Given this list of marker genes GHITM, ARHGEF3, TNFRSF1A, TEFM, CYSLTR2, SLC35A3, RAP1B, ANKRD17, MS4A3 (NCBI Gene Id 95934), CEP19, FKBP1A, PEX13, TGIF1 (NCBI Gene Id 91941), DGKA, ASTN1, RELA, SCIN, ESRP1, SH3BP4, GLA, CACUL1, GALR1, ADAMTS4, GBP4, PEX7, TMEM168, SLC35F6, MTSS1, CREBRF, TAX1BP1, RNF214, C6orf62, IER5, ZFP62, ALCAM, RSBN1, NDUFS4, DNAJB6, BRCA1, CCRL2, DLX1, MOCS2, ARVCF, KLF6, COPZ1, STX2, DNAJB8, ENPP4, PKIG, MRPL30, UPF2, ARL6IP6, RIPK2, TRDMT1, ARMCX3, HERPUD2, UBE2D2, TK1, GOLPH3L, CMTR1, CASP8, CHUK, PCSK7, BCO2, ETV2, ARG1 (NCBI Gene Id 383), BCKDHB, GRAMD1A, KRT81, SLF1, HLA-E, PLOD3, ATP11C, MYO5A, KCTD4, FABP4, MXD1, DUSP1, MAPKAP1, TLR8, UBC, PARP14, ATP11B, OTUB1, SGK1, RNF138, ZNF35, FBH1, NINJ1, PLAT (plasminogen activator, tissue type), KLRK1, STX7, SPN, TMEM45B, LY86, EBI3, IL7R, ZBTB2, LNX2, NMT2, AVL9, TLK2, STK4, TLCD1, IDNK, CSRP1 (cysteine and glycine rich protein 1), UBL5, UBE2R2, DNAJC13, TCAF2 (TRPM8 channel associated factor 2), CD80, RNF114, SELENOT, RNF115, SUOX, SLAMF8, WARS1, HSPA1A, CPEB4, MAPK9, AP3M2, GCNT2, SIRT1, FOS (Fos proto-oncogene, AP-1 transcription factor subunit), PSMA5, TRIP10, TBK1, SLC40A1, FOSB, FYTTD1, CDKN2A, LTA, CLN8, ATG9B, CPNE3, CASP1, MS4A7, STRN3, TASOR2, TRA2A, CHMP4B, DNAJA1, PSMB8, ST3GAL1, PTPN13, COX18, TFG, MRPL27, USF1, GPR19, SMC5, STARD3NL, POLR3A, CABP4, SRPRA, FGF13, CAAP1, NAT1, ATP13A1, LBP, NDRG1, NABP1, HLA-B, TPO, SUGT1, MLXIP, XRN1 (5'-3' exoribonuclease 1), GLIPR2, NECTIN4, UNC93B1, NIPA2, SERPINC1, PITPNC1, CSTF3, GALM, ARF4, CAPRIN1, DCAF15, STAG2 (STAG2 cohesin complex component), MUSTN1, SPOP, NONO, VSX2, ABCB9, RNF34, DDHD1, CBR4, F8 (coagulation factor VIII), MRPL13, SMAP2, DNAJB11, COX15 (NCBI Gene Id 1355), XPO6, GLRX, CPTP, FZR1, MBD2, SARNP, MDM2, TOX4, here is a description of the gene set: from publication Amit I, Garber M, Chevrier N, Leite AP, Donner Y, Eisenhaure T, Guttman M, Grenier JK, Li W, Zuk O, Schubert LA, Birditt B, Shay T, Goren A, Zhang X, Smith Z, Deering R, McDonald RC, Cabili M, Bernstein BE, Rinn JL, Meissner A, Root DE, Hacohen N, Regev A (PMID 19729616) mouse primary BMDCs were stimulated with tlr ligands and gene expression changes were profiled on Affymetrix arrays Human Gene Set: GSE17721_PAM3CSK4_VS_CPG_8H_BMDC_DN Genes down-regulated in comparison of dendritic cells (DC) stimulated with Pam3Csk4 (TLR1/2 agonist) at 8 h versus DC cells stimulated with CpG DNA (TLR9 agonist) at 8 h. studied in species Homo sapiens